The following is a description of a gene set: Any structural anomaly of the aortic valve leaflets. species: Homo sapiens Abnormal aortic valve cusp morphology Human Gene Set: HP_ABNORMAL_AORTIC_VALVE_CUSP_MORPHOLOGY, and this is the list of marker genes: PUF60, RFC2, PPP1R13L, AGO2, MYH7, MMP14 (NCBI Gene Id 4323), FKBP6, BAZ1B, B3GAT3, MYOCD, B3GALT6, NAA10, RAC1, MCTP2, HEY2, TRAF7, YY1AP1, H3-3A, ZFX, FBN2, GJA8, BCAS3, GTF2IRD1 (GTF2I repeat domain containing 1), SMAD2, KMT2D, SKIC2, ABCC9, TGFBR1, ADA2, RAI1, GTF2I, SGO1, TBL2, ZMYM3, MMP2, NADSYN1, DOHH, SKIC3, ZNF462, ACTA2, MYH11, TNXB, ADAMTS19, KIF3B, SCAF4, OGT, LZTR1, PPM1D, FOXF1, TGFB2, FBN1, TMEM270, BCOR, SPTBN1, TAF2, WT1, EDNRA, SRY, LRPPRC, GJA5, TAB2, CBL, SMAD3, CLIP2, H3-3B, TGFB3 (NCBI Gene Id 7043), SNIP1, ARSK (arylsulfatase family member K), GATA5, MLXIPL, DPF2, ZEB2, CAPN15, KANSL1, GTF2IRD2, FLNA, MAT2A, DNAJC30, CHST3, NCF1, SMC3, MFAP5, ARHGAP31, RAP1B, NFE2L2, BUD23, METTL27, SLC25A24, LIMK1, SMAD6, FOXE3, CCNQ, NOTCH3, IFT122, KDM6A, WAC (NCBI Gene Id 55468), MYLK, CREBBP, TGFBR2, THSD4, FDFT1, RPL26, SMAD4, STX1A, NOTCH1, NXN, PRKG1, PPP2R5D, EP300, NIPBL, BBS2, GATA6, VPS37D, PACS1, POLR1A, HNRNPK, ELN, ACTB, ROBO4, LOX, EIF4H, MAP3K7, NKX2-5